Given this list of marker genes MC1R, POLH, HPS1, UROD, OCA2, KRT14, DSTYK, here is a description of the gene set: Human Gene Set: HP_HYPERPIGMENTATION_IN_SUN_EXPOSED_AREAS Hyperpigmentation in sun-exposed areas studied in species Homo sapiens